The following is a description of a gene set: Any process that modulates the frequency, rate or extent of alcohol biosynthetic process. Human Gene Set: GOBP_REGULATION_OF_ALCOHOL_BIOSYNTHETIC_PROCESS studied in species Homo sapiens, and this is the list of marker genes: QKI, DGKQ, MIR98, SEC14L2, MIR185, PTH, PRKACA, SCAP, CLCN2, MIR342, MIR548P, ABCA2, P2RY6, PTH1R, PLEK, LHCGR, AVPR1B, INSIG1, PAQR3, MAPK1, MIR30C1, KPNB1, REST, NTSR1, ABCG4, MBTPS2 (membrane bound transcription factor peptidase, site 2), ERLIN2, MIR182, CYP7A1, APOE, AQP8, ADCYAP1R1, P2RY1, CD244, ERLIN1, GPR146, C7orf50, H6PD, BMP2, PRKAA1, WNT4, SREBF2, DKK3, DAB2, GPER1, ABCG1, LPCAT3, APOB, SREBF1, BMP6, GNAI1, SNCA, BMP5 (NCBI Gene Id 653), MBTPS1, PRKG1, FGF1, MIR96